The following is a description of a gene set: species: Homo sapiens Genes having at least one occurrence of the motif NNNGNCAGTTN in the regions spanning 4 kb centered on their transcription starting sites. This matches the MYB transcription factor binding site V$MYB_Q3 (v7.4 TRANSFAC). Human Gene Set: MYB_Q3, and this is the list of marker genes: ZNF367, ACTC1, C4A, HCN1, C11orf16, SCN3B, PCSK1N, GTF3C2, GNG3, CNOT2, ING3, DGKI, FGF12, SF3B1, EHMT1, KLF5, CSDE1, RBM39, SPATA8, NDUFC1, CDH20, GAN, TMEM80, CHGA, MIDEAS, IER5L, SLC6A20, CADM2, SSBP2, RIMS1, PTCHD4, NEUROD6, RFX3, PREB, RAB2A, YWHAQ, SKAP1, STC1, NEDD8 (NEDD8 ubiquitin like modifier), PRICKLE1, CANX, HOXB3, ZMYND8, MXD3, OPCML, MYO18B, PNOC, PAN2, ZNF362, WIPI1, ZSWIM2, PCDH9, SEC16B, UBE2R2, ZBTB32, PRUNE1, TPI1P2, ANKRD17, GNAT1, CACNA1G, VCPIP1, HOXA11, OAZ2, SECISBP2, OMG, MROH2B, NR3C2, PPARGC1B, ZBTB26, ALDOA, PHF7, SRSF5, ORAI3, C4B (complement C4B (Chido/Rodgers blood group)), LIG4, DSCAM, ARL4C (ADP ribosylation factor like GTPase 4C, NCBI Gene Id 10123), VAV1, SPAG9, NRGN (neurogranin), FOXP1 (forkhead box P1), TOR1AIP1, HEBP1, FXR2, GNAS, ESRRG, CASK, HERPUD2, SPOCK2 (NCBI Gene Id 9806), TMEM62, RHOBTB3 (NCBI Gene Id 22836), MYL6B, DNAH12, PPP4R4, CACNB3, WNT3, EPB41, B3GALT2, FLI1, TUG1, GNL1, TMEM132E-DT, PRDM13, MDGA2, GRK5, YWHAE, HSPA9, BSCL2, C1orf21, CSTF1, TEX47, CADM1, UBE2H, TRIM2, STT3B, MAP4, ZNF148, KRT25, SHMT1, TSC22D1, NDEL1, MED13, LNPEP, AHNAK, SEPTIN12, RAPSN, ZMYM2, SLC6A10P, HRH4, NIPBL, PIK3CG, USP32, ZBTB47, RIN1, ABHD2, FIGN, GCAT (glycine C-acetyltransferase), DMD, USP5, ODF2, MYOZ2, P2RY2, LYN, CEBPB, AURKA (aurora kinase A), E4F1, SORT1, PDAP1, TAF5, ZNF462, FRAS1, LTBP1, BHLHE22, ANKZF1, TMEM132E, KMT2D, GOLGA7, BUD31, IL11RA, ANKRD28, COX7A2P2, TP53I13, BDNF, ASIC2, GBA2, COL12A1, BEND4, NMUR1, HMGA2, PRDM16, PNMA1, RARG, HHEX, WNT5A, FAM13B, SRGAP2, LINS1, CCL5, LMNA, CNTF, ARHGEF6, MAZ, RPL4, SHKBP1, SLC16A6, MIR22HG, NCOA5, C19orf47, RDH11, PIK3R3, RASA3, SESN2, GMPR2, FOXF2, MBD6, KMT2E, KLF12, CELF1, CDK2, TMEM97, ETV4, TOX2, BAP1, TNPO3, ORMDL2 (ORMDL sphingolipid biosynthesis regulator 2), LEP, ASB7, RGS2, PRR3, MTRFR, CRISPLD1, PRPF38B, PTMS, SYNC, NOVA1, CDCA3, VAPA, DDIT3, MINDY1, RREB1, NRF1, GMFG, CAMK2A, ABHD15, WDR81, NRXN3, AGER, CCDC171, CD68, RUNX1T1 (NCBI Gene Id 862), SEMA7A, LAMA3, XPO1, UBE3A, PMEL, HNRNPF, MGLL, GPHN, ERRFI1, PLXNC1, ID4, SOX5, TOB1, ERGIC1, TNNI1, ATG9A, AP5B1, ZNF800, LHX6, LUC7L3, MLN, ESRRA, CLTRN